The following is a description of a gene set: Mouse Gene Set: GOBP_CHLORIDE_TRANSPORT species: Mus musculus The directed movement of chloride into, out of or within a cell, or between cells, by means of some agent such as a transporter or pore., and this is the list of marker genes: Gabra4 (gamma-aminobutyric acid type A receptor subunit alpha 4), Slc26a8, Slc4a9, Gabrg2, Slc26a1, Slc26a6, Slc17a7, Gabrq, Gabrb3, Slc26a7, Gabrp, Slc26a9, Slc12a9, Car2, Slc4a3, Slc25a27, Clic1, Slc6a2, Ano8, Clcn6, Clic4, Car7, Prkg2, Cftr, Slc1a7, Chrm5, Oca2, Slc12a1, Gabra3, Clcnka, Ano3, Ano1, Clcc1, Wnk4, Kcnk2 (potassium channel, subfamily K, member 2), Ano7, Gabre (NCBI Gene Id 236851), Clcn4, Ttyh2, Ano6, P2ry4, Pcyox1, Clcnkb, Glra1, Slc12a3, Apol11a, Glra3, Gabra2, Best2, Ostm1, Clca4a, Slc6a1, Slc12a6, Gabra5, Slc25a14, Slc26a10, Clic3, Slc4a1, Clic5, Ano2, Bsnd (NCBI Gene Id 269570), Gabrb2, Slc17a6, Glrb, Clca2, Ucp2, Clcn3, Abcb1b, Slc26a2, Slc26a3 (NCBI Gene Id 80590), Ttyh3, Tspo, Best1, Slc4a8, Clic6, Gabrg3, Slc1a1, Slc12a7, Slc26a5, Gabrr2, Slc6a14, Atp8b1, Slc5a8, P2ry6 (pyrimidinergic receptor P2Y, G-protein coupled, 6), Tmc4, Clcn1, Lrrc8a, Clca3a1, Slc12a2, Gabrr3, Cldn4, Slc12a4, Slc4a2, Slc26a4, Kcnk1, Ttyh1, Mfsd8, Casr, Clcn5, Best3 (bestrophin 3), Gabra6, Nmur1, Glra2, Slc12a5, Gabrg1, Slc1a4, Glra4, Gabrr1, Slc26a11, Clcn7, Clcn2, Abcb1a, Ano10, Pacc1, Clca1, Gabrb1, P2rx5, Nmur2, Slc17a8, Ano5, Slc12a8, Cldn17, Slc1a3, Ano9, Gabra1, Gabrd, Ano4, Clns1a, Aqp6, Clca3a2